The following is a description of a gene set: Mouse Gene Set: MP_INCREASED_TUMOR_LATENCY Mouse genes annotated to increased tumor latency (MP:0009828) retrieved from the Mouse Genome Informatics database via MouseMine from publication Motenko H, Neuhauser SB, O'Keefe M, Richardson JE (PMID 26092688) studied in species Mus musculus, and this is the list of marker genes: Trp53, Kras, Prf1, Pard3, Cacfd1 (calcium channel flower domain containing 1), Setd4, Trem1, Mgat5, Ifng